The following is a description of a gene set: Any process that decreases the frequency, rate or extent of the chemical reactions and pathways involving triglyceride, any triester of glycerol. species: Mus musculus Mouse Gene Set: GOBP_NEGATIVE_REGULATION_OF_TRIGLYCERIDE_METABOLIC_PROCESS, and this is the list of marker genes: Apoe, Cidec, Srebf1, Apobec1, Plin5, Apoc3, Cdk8, Pik3cg, Nr1h4, Ccnc, Esr1, Tmx1, Sik1 (salt inducible kinase 1), Gpld1, Sirt1, Sorl1